Given this list of marker genes AMBP, DEPP1, INHBC, HPRT1, STEAP1, TMEM158, PROM1, IL32, TBX1, TGFBR2, EMP1, S100A11, SOX4, CSRP2, HAP1, CDV3, POLD2, PLOD2, SCHIP1, CHST3 (NCBI Gene Id 9469), LAMB1, CBX1, DAB2, GMPS, CXCR4, TGFBI, PSPHP1, EMP2, MFAP2, NUP205, ARID1A, TYRO3, GNG12, KRT86, CASP2, APOH, SEMA6C, RCN2, KRT7, GC, PFKFB2, CDC20, ESPL1 (extra spindle pole bodies like 1, separase), DUSP6, IFI16, CD24, ST6GALNAC4, MSMO1, EPAS1, IGF2, LDLR, SEC11A (SEC11 homolog A, signal peptidase complex subunit), ITPR3, ANXA1, PTP4A3, CDKN2C, TFRC, MAOB, THBS1, ANXA3, TM4SF1, OGG1, FHL2, PRELID3A, RND3, STAU1, TNFRSF10B, TPM2, LAPTM5, CDKN3, GDF15, AMELX, PLK1, PKMYT1, RRM1, SCAMP5, IL1RAP, DBN1, JUNB, LSM1, TRAM2, HAT1 (NCBI Gene Id 8520), CALD1, MSX1, LMO2, WEE1, VEGFA, CXCL8, PRPF19, LPGAT1, KLHDC3, AP1M1, RAC3, BTBD3, FST, ACSL3, ILF3, ZWINT, CCN1, DLGAP5, MYO10, GART, IFIT1, MAFF, FADS1, SLC2A1, GBE1 (1,4-alpha-glucan branching enzyme 1), PTS, RPS26, EFEMP1, SPOCK1, TPX2, GTSE1, MCRS1, CST7, RAB11A, ALCAM, ANXA2, APOB, SLC7A11, NUP50, TNNT1, NPAS1, MSH6, COPS3, PON2, UGDH, PAX9 (NCBI Gene Id 5083), ADIPOR2, INSIG1, E2F3, H2BC21, PCNA, RBP1, APOC1, TPM1, H2AX, THBS2, LMNB1, UBE2C, TMEM259, COL5A2 (collagen type V alpha 2 chain), RPA3, E2F1, BMP1, PRAME, SCP2, DNM2, CD151, IGFBP2, COX7B, MYBL2, ORM2, STMN1, CCL15, GET1, SLC16A3 (solute carrier family 16 member 3), CKS2, NOLC1, FCGRT, NRG2, GOT1, QSOX1, PECAM1, GAGE12G, PCOLCE, DDX21, ENG, SNRPB2, CLDN9, DDIT4, SOX10, RAI14, CENPA, CCT6A, CNN3, SLC22A18AS, KRT18, MAGEA3, SLC39A6, NTS, CTSC, GRN (granulin precursor, NCBI Gene Id 2896), MCM3, TIMP3 (NCBI Gene Id 7078), ODF1, ETFB, LOX, AK2, DDX3Y, IKBKG, SSR1, ECHS1, LIF, H2BC12, PLIN2, COL2A1, GJA1, SRSF2 (NCBI Gene Id 6427), PAICS, PRPSAP1, RRM2, ITGA6, SEMA3C, FILIP1L, GAS1, GULP1, AKAP12, CITED2, CDC45, CDK2, KRT19, SLC7A5, CCL2, SGCE, M6PR, ALDH7A1, SERPINA1, BUB1B, ADAM9, SRPX, ETV5, AGT, MGLL, ITPA, OCLN, CKAP5, PER1, MACIR, NQO1, EFNA2, EZH2, ACTN1, FADS2, RFC4, MAPRE1, HSPG2, GGH, SWAP70, DSP, CDK1 (cyclin dependent kinase 1), RGS5, AKR1C3, FGFR1 (NCBI Gene Id 84151), LAIR1, CAVIN1, SPP1, COL9A3, PEPD, CHST1, MDK, PSMA4, RBP4, DDX17, CCNF (NCBI Gene Id 899), SRGN, HTR4, TYR, VWF, TNF, GPNMB, IER3, ZYX, RNASE1, TMX1, EPCAM (NCBI Gene Id 4275), SFRP1, RCC1, DDT, PIR, GPC3, S100A4, GAGE12F, EPS8, DKK4, SYNGR4, MAGEA2, RNASEH2A, ANGPT1, GNG11, TIMP2, FGB, FLNA, PDLIM4, LY6G6C, CYB5A, FABP4, CDKN2A, IGSF3, CD22, ALB, HTRA2, NNMT, WIZ, TTK, UCK2, TMED3, CALU, SRPK1, CAP2, AANAT, CIAO1, CCNB1, DPYSL3, ASNS, TSPAN3, CCNB2, GJB1, H1-2, UBXN1, PDIA4 (protein disulfide isomerase family A member 4), CARD10, PROCR, SERBP1, EPB41L3, UMPS, STAB1, TRIP13, PLAT, NUDT1, TMEM106C (transmembrane protein 106C), CAV1 (caveolin 1), TOP2A, EPHA2, CENPF, YWHAE, DTYMK, UNG, QPCT (glutaminyl-peptide cyclotransferase), BOP1, ITGB5, ALDH1A1, DLK1, COL4A1, EIF4EBP1, IFI27, LTBR, PCLAF, PTTG1, MAT1A, PPP4R1, WWTR1, SERPINE1, PPT2, DDIT3, CRIM1, FGFR3, MCM6, FOXM1, CSE1L, PHLDA2, SVIL, PRSS2, MEST, PDGFRA, KCND3, MMP1, CHAF1A, MMD, FN1, CDH2, FEN1, ANPEP, SERPINH1, SYNCRIP, PLK2, SMTN, PRSS23, ID2B, PRB4, ACR, POU4F1, CLDN5, PKIA, KIF11, CAV2, ITGA3, PDE4B, VSIG4, CHPF, MCM2, CCNA2 (cyclin A2), LMNB2, MLLT11, ZMPSTE24, BIRC2, PNP, ISG15, RAC2, RIBC2, FDPS, PLSCR1, TGM2, ST6GAL1, PLEC, SNRPC, CXCL1, FDXR, CDC25B, LOXL2, TRPC4AP, HMMR, KIFC1, SORD, KRT4, ARFIP2, MAD2L1, RRP1B, DOLK, APOE, TM4SF4, CSNK2A1, LGR5, GYG1, EEF1E1, NHERF1, IGFBP4 (NCBI Gene Id 3487), SERPINA6, SDC1, IGF2BP3, ADSL, PSMC2, MYC, PEG10, H4C3, ZIC2, MAGEA4, EMP3, CDKN1A, TNC, FAT1, RRP9, here is a description of the gene set: Human Gene Set: MODULE_52 Cell line expressed genes. species: Homo sapiens